Given this list of marker genes GTF2H2, H2AC14, TAF1A, TAF1C, POLR1E, H2BC9, H2BC5, POLR2F, SAP130, H2BC3, ARID4B, ERCC3, H3C15, POLR2K, H2AC18, H2BC13, H3C1, POLR1F, GTF2H4, POLR1H, H2AC6, SAP30L, H2BC12, GTF2H3, TAF1B, H2BC11, H2AB1, MNAT1 (NCBI Gene Id 4331), H2AC20, H3-3A, BAZ2A, 18S rRNA, 5.8S rRNA, 28S rRNA, CCNH, H2AC4, H2BC15, SIN3B, HDAC2, SMARCA5, POLR1B, TBP, H2AZ2, H2BC1, H2BC14, POLR2L, H2AX, HDAC1, H2BC4, H2BC17, ERCC2 (NCBI Gene Id 7269), GTF2H1, UBTF, H2AJ, H4C1, TAF1D, DNMT3B, H2BC21, SAP18, H2AC7, CDK7, H2BC26, POLR1D, POLR1G, SUDS3, SAP30, DNMT1, POLR2E, TTF1, H2BC12L, POLR1C (NCBI Gene Id 9533), SIN3A, GTF2H5, POLR1A, POLR2H, SAP30BP, MBD2, 45S pre-rRNA gene, here is a description of the gene set: part of: Negative epigenetic regulation of rRNA expression species: Homo sapiens The Nucleolar Remodeling Complex (NoRC) comprising TIP5 (BAZ2A) and the chromatin remodeller SNF2H (SMARCA5) silences rRNA gene. The TAM domain of TIP5 (BAZ2A) binds promoter-associated RNA (pRNA) transcribed from the intergenic spacer region of rDNA. The pRNA bound by TIP5 is required to direct the complex to the main promoter of the rRNA gene possibly by triple helix formation between pRNA and the rDNA. The PHD domain of TIP5 binds histone H4 acetylated at lysine-16. Transcription Termination Factor-I (TTF-I) binds to a promoter-proximal terminator (T0 site) in the rDNA and interacts with the TIP5 subunit of NoRC. NoRC also interacts with the SIN3-HDAC complex, HDAC1, HDAC2, DNMT1, and DNMT3B. DNMT3B interacts with a triple helix formed by pRNA and the rDNA. HDAC1, DNMT1, and DNMT3B have been shown to be required for proper DNA methylation of silenced rRNA gene copies, although the catalytic activity of DNMT3B was not required. Reactome Pathway: NoRC negatively regulates rRNA expression